Given this list of marker genes Grb2, Hgf, Gab1, here is a description of the gene set: electronically inferred by orthology from the curated human pathway species: Mus musculus This event has been computationally inferred from an event that has been demonstrated in another species.<p>The inference is based on the homology mapping from PANTHER. Briefly, reactions for which all involved PhysicalEntities (in input, output and catalyst) have a mapped orthologue/paralogue (for complexes at least 75% of components must have a mapping) are inferred to the other species. part of: Signaling by MET Reactome Pathway: MET activates PTPN11